The following is a description of a gene set: Human Gene Set: HP_DEFORMED_SELLA_TURCICA Deformed sella turcica studied in species Homo sapiens, and this is the list of marker genes: PTCH2, TRIM37, PLOD3, DYM, SUFU, FLNA, MAF, NOTCH2, GUSB, MTX2, POP1, GNPTAB, ADAMTSL2, OBSL1, VPS33A, IDUA, ALDH18A1 (aldehyde dehydrogenase 18 family member A1), PTCH1, SLC17A5, RMRP